The following is a description of a gene set: Human Gene Set: REACTOME_INTERLEUKIN_15_SIGNALING Interleukin-15 signaling studied in species Homo sapiens, and this is the list of marker genes: STAT3, GRB2, STAT5B, IL2RG, SHC1, SOS1, IL15, JAK1, IL2RB, GAB2, SOS2, JAK3 (Janus kinase 3), STAT5A, IL15RA